The following is a description of a gene set: A behavioral interaction between organisms in which one organism has the intention of inflicting physical damage on another individual. Human Gene Set: GOBP_AGGRESSIVE_BEHAVIOR studied in species Homo sapiens, and this is the list of marker genes: OXT, NR2E1, AVPR1A, KIRREL3, GCNT4, CRHBP, AVP (arginine vasopressin), TACR1, PENK